The following is a description of a gene set: TMPRSS2-ERG fusion to transcriptional activation. Pathway ID: N00128. Pathway type: Variant. Pathway class: nt06272 Prostate cancer. Pathway Definition from KEGG: TMPRSS2-ERG => (PLAU,PLAT,MMP3,MMP9,ZEB1,IL1R2) species: Homo sapiens Human Gene Set: KEGG_MEDICUS_VARIANT_TMPRSS2_ERG_FUSION_TO_TRANSCRIPTIONAL_ACTIVATION, and this is the list of marker genes: ZEB1, MMP9, IL1R2, MMP3, PLAU, ERG, PLAT